Given this list of marker genes Rnase10, Zp2, Ccdc87, Ints13, Myh9, Prss37, Nlrp5, Park7, Astl, Plcb1, Adam24, Plat, Wee2, Fam170b, Lhfpl2, Zp1, Cfap69, Prdm9, Tpst2, here is a description of the gene set: studied in species Mus musculus Any process that modulates the rate, frequency or extent of fertilization. Fertilization is the union of gametes of opposite sexes during the process of sexual reproduction to form a zygote. It involves the fusion of the gametic nuclei (karyogamy) and cytoplasm (plasmogamy). Mouse Gene Set: GOBP_REGULATION_OF_FERTILIZATION